The following is a description of a gene set: Human Gene Set: GOBP_REGULATION_OF_MACROPHAGE_ACTIVATION studied in species Homo sapiens Any process that modulates the frequency or rate of macrophage activation., and this is the list of marker genes: MIF, SPHK1, LRFN5, TREM2, MIR145, TLR4, IL1RL1, LDLR, MFHAS1, HAVCR2, MMP8, IL4R, IRGM, CEBPA, CTSC (NCBI Gene Id 50958), CCL3, FCGR2B, PTPRC, PLA2G4A, FAM76B, JUND, THBS1, SPACA3, NR1D1, MIR142, KARS1, SHPK, TTBK1, MCUB, ADGRF5, CALHM2, TLR6, SYT11, VSIG4, CD200, CST7, MYO18A, MIR130A, HSPD1, PJA2, IL13, TAFA3, CX3CL1, LRRK2, ZC3H12A, IL6, BPI, WNT5A, STAP1, RORA, NR1H3, SNCA, IL31RA, IL10, MIR128-1, GRN, GPR137B, CD74, IL33, TNIP2, LBP, PLA2G10 (NCBI Gene Id 8399)